The following is a description of a gene set: species: Homo sapiens Human Gene Set: HP_PHOTOPSIA Perceived flashes of light. Photopsia, and this is the list of marker genes: ZNF408, PRPF3, BAP1, BBS1, CYSLTR2, MAK, ARL6, SEMA4A, REEP6, SPATA7, BEST1, PRPH2, PCARE, RP2, CRX, PDE6G, RPE65, IMPG2, RPGR, PRPF31, ARL2BP, MERTK, SCAPER, SLC7A14, KIAA1549, ATP1A2, CA4, IDH3A (NCBI Gene Id 3419), CACNA1A, TTC8, OFD1, CERKL, IMPDH1, KLHL7, IDH3B, CC2D2A, IFT172, RP1, CNGB1, ROM1, IMPG1, SF3B1, CRB1, SAG (S-antigen visual arrestin), PDE6B, ABCA4, KIZ, RGR, CFAP418, FSCN2, PRPF8, PDE6A, TULP1, HGSNAT, TUB, RLBP1, RHO, SNRNP200, PRCD, IFT88, NEK2, CLRN1, NR2E3, PRPF4, RP9, CNGB3, GNAQ, RP1L1, POMGNT1, IFT140, CDHR1, EYS, ARHGEF18, LRAT, PRPF6, RBP3, BBS2, TOPORS, GUCA1B (guanylate cyclase activator 1B), ARL3, AGBL5, ELOVL4, GNA11, SCN1A, AHI1, DHDDS, FAM161A, NRL, AHR, CNGA1, PROM1, ZNF513, USH2A, RDH12, DHX38, PRRT2